Given this list of marker genes Acp5, Nod2, Twist2, Tnf (tumor necrosis factor), Hmox1, Tgfb2, Bcl6, Arg1, Twist1, Cd96, Vsir, Angpt1, Apoa1, Cuedc2, Ifnb1, Atg9a, Axl, Lilrb4a, Lilrb4b, Tbx21, Slamf1, Bst2, Hfe, Rabgef1, Apoa2, Irak3, Smad7, Nlrx1, Tgfb3, Prg2, Il10 (interleukin 10), Tgfb1, Foxp3, Jak3, Epx, here is a description of the gene set: Any process that stops, prevents, or reduces the frequency, rate, or extent of cytokine production contributing to an immune response. studied in species Mus musculus Mouse Gene Set: GOBP_NEGATIVE_REGULATION_OF_CYTOKINE_PRODUCTION_INVOLVED_IN_IMMUNE_RESPONSE